The following is a description of a gene set: part of: SLC transporter disorders The human gene SLC35A1 encodes the CMP-sialic acid transporter which mediates the antiport of CMP-sialic acid (CMP-Neu5Ac) into the Golgi lumen in exchange for CMP. Defects in SLC35A1 are the cause of congenital disorder of glycosylation type 2F (CDG2F; MIM:603585), characterised by under-glycosylated serum proteins. CDGs are a family of severe inherited diseases caused by a defect in protein N-glycosylation. These multisystem disorders present with a wide spectrum of phenotypes such as disorders of nervous system development, psychomotor retardation, dysmorphic features, hypotonia, coagulation disorders and immunodeficiency. studied in species Homo sapiens Reactome Pathway: Defective transport by SLC35A1 causes congenital disorder of glycosylation 2F (CDG2F), and this is the list of marker genes: SLC35A1